The following is a description of a gene set: studied in species Homo sapiens Chronic unloading of the failing heart with a left ventricular assist device (LVAD) can decrease cardiac mass and myocyte size and has the potential to improve contractile function. To study the effect of chronic ventricular unloading on myocardial gene expression, a microarray (U133A, Affymetrix) profiling gene expression was compared before and after LVAD support in seven patients with idiopathic dilated cardiomyopathy and end-stage heart failure. On average, 1,374 +/- genes were reported as increased and 1,629 +/- 45 as decreased after LVAD support. A total of 130 gene transcripts achieved the strict criteria for upregulation and 49 gene transcripts for downregulation after LVAD support. Upregulated genes included a large proportion of transcription factors, genes related to cell growth/apoptosis/DNA repair, cell structure proteins, metabolism, and cell signaling/communication. LVAD support resulted in downregulation of genes for a group of cytokines. To validate the array data, 10 altered genes were confirmed by real-time RT-PCR. Further study showed that the phosphoinositide-3-kinase-forkhead protein pathway and proteins related to nitric oxide synthesis, including eNOS and dimethylarginine dimethylaminohydrolase isoform 1 (DDAH1, an enzyme regulating endogenous nitric oxide synthase activity), were significantly increased during the cardiac remodeling process. Increased eNOS and DDAH1 expression after LVAD support may contribute to improved endothelial function of the failing hearts. Up-regulated genesin the left ventricle myocardium of patients with heart failure following implantation of LVAD (left ventricular assist device). from publication Chen Y, Park S, Li Y, Missov E, Hou M, Han X, Hall JL, Miller LW, Bache RJ (PMID 12824457) Human Gene Set: CHEN_LVAD_SUPPORT_OF_FAILING_HEART_UP, and this is the list of marker genes: PLIN2, MT2A, ZBTB16, TMEM204, DDAH1, CDC42EP4, CDC37L1 (NCBI Gene Id 55664), NFIL3, JUN, AGTR1 (angiotensin II receptor type 1), RGCC, RNF115, DIXDC1, VCL, PIK3R1, CDKN1A, AOPEP, CCN1, IRS2, FSTL3, XK, MT1E, NID1, TXNIP, MYOM1, TSC22D3, CALD1, SLC38A2, RND3, TIMP4, SERPINE1 (serpin family E member 1), INSR, AMD1, ZFAND5, ELF1, KLF2, ZNF189, CEBPD, BCL6, CHST3, MTHFD2, CEBPB, ZFP36, CSDC2, SLCO4A1, PDK4, DDIT4 (DNA damage inducible transcript 4), TIMP3, POSTN, FOSL2, MT1F, ANKRD2, TCAP, ACTA1, MYOT, CYP4B1, NFKBIA, BTG2, TIPARP, GADD45G, PER1, KLF9, FNDC3B, NCKIPSD, MAPRE2, FHL1, SH3BGR, SYNPO2L, CCN2, DNAJB5, PLPP1, AREG, CD163, TMT1A, NES, CNN1, ATF3, SNAI2, MCL1, REV1, CCNB1IP1, DEPP1, ANKRD1, RERE, GADD45B, KCNK1, ZBTB20, LAMB1, MT1H, DOCK9, CLU, MT1X, MT1M, PLA2G5, RRAS2, GLUL, MFAP4, FKBP5, FOXO3, HYAL2, IER5, FLNC